The following is a description of a gene set: We identified Pparg as a major orchestrator of the phenotype of adipose-tissue resident regulatory T cells (VAT Tregs). To establish the role of Pparg in shaping the VAT Tregs gene profile and cell dynamics, Tregs from lymph nodes and visceral adipose tissue of mice sufficient and deficient of Pparg expression in Tregs were double sorted for microarray analysis. studied in species Homo sapiens Human Gene Set: GSE37532_TREG_VS_TCONV_CD4_TCELL_FROM_VISCERAL_ADIPOSE_TISSUE_UP Genes up-regulated in visceral adipose tissue of aged mice: T reg versus T conv. from publication Cipolletta D, Feuerer M, Li A, Kamei N, Lee J, Shoelson SE, Benoist C, Mathis D (PMID 22722857), and this is the list of marker genes: NEFM, MIR541, CXCL12, ANXA8 (annexin A8), ENC1, PAX9, AQP4, MYBPC3, MIR383, PTPN3, TMEM61, SPATA31F3, LMCD1, SYCP1, MOBP, MIR500A, ASGR1, NALF2, EPN3, TCAM1P, TRPM2 (transient receptor potential cation channel subfamily M member 2), PRTN3, RAB3IL1, SIGLEC5 (NCBI Gene Id 8778), BPIFB1, SPATA20, AGMAT, BEND7, GUCY2D, HTR3A, KIF26B, DNER, TSPAN11, CDA, PELO, USP43, HRH3, MAPK8IP2 (mitogen-activated protein kinase 8 interacting protein 2), CALHM1, SLC16A12, ABCG8, LEMD1, CHRDL2, CPN2, PI16 (NCBI Gene Id 221476), RGS5, ALK, GPR141, CRYBA1, TMEM89, SVIP, SLC22A3, THBS2, USP44, SYCE1, DTNA, BMP8A, ATP2C2, PRRT3, SLC38A5, GAL3ST1, BCAN, CAPN9, FNDC7, SYT8 (synaptotagmin 8), DLK2, SEMA3G, GLOD5, ADGRB1, RHPN1, HMGN2, MRGPRX1, P3H3, STBD1, GPR139, COL4A5, XCL1, NEFL, NES, MRC2, CES4A, PERP (p53 apoptosis effector related to PMP22), GPR6, NHLH1, EREG, CPA4, CNDP1, CBLC, TOX2, HPD, TMPRSS7, ATF7IP2, SLC7A8 (NCBI Gene Id 23428), INPP5J, SRPX2, KRTAP5-2, RTP3, HOXC10, CLDN5, SLITRK5, ARHGAP22, SLC25A48, CTNND2, DCAF12L1, PACSIN3, MYH7B, TNR, MUC20, ABCC8, PDE6B, RSPH10B2, CAMK2A, MFSD6L, DAPK2, ADGRF1, GAP43, ADCY4, TRPV6, PAPPA2, FBXO2, ACBD7, ALLC, KCNV1, ROBO2, ME1, USP17L5, LOX, SMTNL1, GSTO2, MADCAM1, OGDHL, GRM5, DAB2IP, ROBO3, RXFP4 (NCBI Gene Id 79359), SP9